Given this list of marker genes Lif, Fam3c, Cdk5, Cdk5r1, Mir301 (microRNA 301), Ifng, Ret, Ercc6, Ifnb1, Gadd45a, here is a description of the gene set: The process of introducing a phosphate group to a serine residue of a STAT (Signal Transducer and Activator of Transcription) protein. Mouse Gene Set: GOBP_SERINE_PHOSPHORYLATION_OF_STAT_PROTEIN studied in species Mus musculus